The following is a description of a gene set: studied in species Homo sapiens Onset of disease at an age of greater than or equal to 16 to under 19 years. Early young adult onset Human Gene Set: HP_EARLY_YOUNG_ADULT_ONSET, and this is the list of marker genes: CNNM2, TLR7, KCNE1, LIG3, HROB, CLCN1, SERPINA1, EIF2AK2, BVES, PRKRA, RNF216, ALG10B, ERCC6L2 (NCBI Gene Id 56959), UNC13D, SLC4A4, TTN, TLR8, SMN2, NRCAM, SEMA3A, KCNJ5, SOHLH1, SNTA1, DNAJC3, SCARB2, CARD9, ESR2, REEP6, HGSNAT, GYG1 (NCBI Gene Id 2992), COL2A1, DSP, KCNA5, CEBPE, B4GALNT1, REEP1, LHB, TWNK, POLG, B2M, GPIHBP1, WNT4, PMP2, SELENBP1 (NCBI Gene Id 8991), HCN4, KCTD17, STAT1, TRNT1, PIK3R5, TPP1, KCNJ2, HTRA1, TOR1AIP1, PRRT2 (NCBI Gene Id 81865), LMNA, SPTLC1, RRAGD, DGKE, KASH5 (NCBI Gene Id 94029), KCNH2, INS, SMN1, P2RX2, PRKN